Given this list of marker genes DRAM1, GRAMD2B, SOX2, ABCC5, ID1 (inhibitor of DNA binding 1), FAM110C, RPRM, SGCG, RND3, S1PR3, DRD1, ST8SIA4, TUFT1, CCN2, ATP6V0A4, CYP1A1, RNF144B, CLIP4, ITGB6, IGDCC3, SLIT2, ELF5 (E74 like ETS transcription factor 5), DAB2 (NCBI Gene Id 1601), PMP22, ID3, CDK6, BMF, HCAR2, TNFRSF11B, TGFB2, PLK2, CDKN2B, CFAP206, TGFB3, NUAK1 (NUAK family kinase 1), RNF43, KCNJ8, GRHL3, here is a description of the gene set: Human Gene Set: LI_ESTROGENE_MCF7_E2_RESPONSE_DN from publication Li Z, Li T, Yates ME, Wu Y, Ferber A, Chen L, Brown DD, Carroll JS, Sikora MJ, Tseng GC, Oesterreich S, Lee AV (PMID 37272757) species: Homo sapiens As one of the most successful cancer therapeutic targets, estrogen receptor-alpha (ER/ESR1) has been extensively studied over the past few decades. Sequencing technological advances have enabled genome-wide analysis of ER action. However, comparison of individual studies is limited by different experimental designs, and few meta-analyses are available. Here, by ingesting large amount of E2-related transcriptomic data sets in breast cancer cell lines, we identified gene expression changes across 66 RNA-seq and 80 microarray experiments based upon the E2-induced fold change in gene expression. MCF7 and T47D cell lines have been used extensively as ER+ breast cancer models. However, extrapolation of this data to breast cancer is complicated by the known heterogeneity of breast cancer and potential biases arising from cell line-specific results. Importantly, while EstroGene contains transcriptomic data from 19 different breast cancer cell lines, data from MCF7 and T47D account for ~50% and ~20%, respectively, of all experiments. To characterize and describe contextual cell-line specific responses, we identified the top 10th percentile of upregulated and downregulated genes in an individual study and consistent among 50% of comparisons within MCF7 or T47D experiments. For non-MCF7/T47D experiments we lowered the threshold to 40% across studies due to the larger heterogeneity in this subset. Intersection of the three subsets yielded 89 and 96 uniquely regulated genes in MCF7 and T47D, we also identified genes that were not regulated in MCF7 and T47D but showed E2-induction in some other cell lines. High confident estrogen down-regulated genes exclusively in MCF7 cells merged from 74 NGS datasets-based comparisons (10% topmost down-regulated genes and consistent in at least 50% comparisons).